The following is a description of a gene set: Human Gene Set: MIR6823_5P Genes predicted to be targets of miRBase v22 microRNA hsa-miR-6823-5p in miRDB v6.0 with MirTarget v4 prediction scores > 80 (high confidence targets). from publication Chen Y, Wang X (PMID 31504780) studied in species Homo sapiens, and this is the list of marker genes: WNT10B, PDK2, NIPAL3, UBN2, ASCL1, SLC24A2, EPGN, PHLDB2, ARID4A, SCN5A, TMEM108, PDYN, STX17, ARID1A, ATF3, BANK1, JAKMIP3, AFG1L, KBTBD13, SPOP, WNT3, CYP4F11, GPR3, VAMP1, PTPN12, MBTPS1, RRP15, MLXIP (MLX interacting protein), PCDHB9, POU2F1, DYNAP, SENP8, STAG2, PTP4A2, EFHC1, OPRPN, COL22A1, CUX2, SORCS1, AASDH, ZCWPW2, GPC6, ABHD17B, KIF24, AAK1, FAT1, OTX2, ZNF677, ERMN, RTL10, CNOT4, L2HGDH, NPEPPS, FAM8A1, EPHX3, ARCN1, SOX6 (NCBI Gene Id 84363), SETD2, PCDH18, PPP5D1P, CXXC4 (CXXC finger protein 4), RIMS3, ZIM3, TAF1D, MYPOP, DTNA, NPHS2, SERPINB8 (serpin family B member 8), CAPN15, HS6ST1